The following is a description of a gene set: species: Homo sapiens The synthesis or release of any molecular mediator of the immune response, resulting in an increase in its intracellular or extracellular levels. Human Gene Set: GOBP_PRODUCTION_OF_MOLECULAR_MEDIATOR_OF_IMMUNE_RESPONSE, and this is the list of marker genes: TCF3, POLL, B2M, F2RL1, XCL1, STAT6, FFAR3, BATF, CLCF1, CD86, PRKDC, UNG, SAMHD1, CAMK4, IRAK3, GATA3, CD22, NFKBIZ, SANBR, APOA1, PMS2, IL4, IL17A, CD7, MZB1 (NCBI Gene Id 51237), ATG9A, POLM, CALHM6 (NCBI Gene Id 441168), IFNA2, SHLD3, CD40LG, SASH3, AICDA, KLK7, NHEJ1, IL6, MSH3, KMT5C, IL2RG, NLRP3, EXOSC6, PRKCZ, RIGI, EPHB2, ELANE, LILRB1, POLB, PLCG2, TWIST1, IL18, STX4, CD74, TICAM1, IFNB1, RAET1G, KMT5B, TLR3, TP53BP1, SEMA7A, GPI, SHLD2 (NCBI Gene Id 54537), CGAS, TRAF3IP2, SMAD7, PHB1, IL27RA (NCBI Gene Id 9466, interleukin 27 receptor subunit alpha), NOD1, CYREN, MSH6, MCM3AP, TNF, BTK, ZPBP2, CD226, SWAP70, PRG2, CLNK, BCL6, XRCC4, IL21, PKN1, HK1, ARID5A, TNFRSF14, YY1, IL13RA1, ANGPT1, CLEC7A, UBE2J1, VAMP3, SLC7A5, NLRX1, AXL, SPON2, MMP7, TMBIM6, RTN4, BCL10, CTNNBL1, TREX1, ATG5, SIRT1, CCR6, TRIM6, APOA2, TNFRSF1B, IL33, LILRB4, LITAF, CD244, SLAMF1, MAPKAPK2, ATAD5, CD36, SHLD1, PARP3, HFE, LGALS4, SPHK2, MAP3K7, NBN, EXOSC3, MIR302A, HLA-G, TLR4, JAK3, IL10, POLQ, IL1R1, IL18R1, P2RX7, CD81, C17orf99, EPX, CD28, IL17F, HLA-A (NCBI Gene Id 3105), PCYT1A, MLH1, ARG1, ERCC1, DEFB131A, MIF, KIR2DL4, TLR9, RBP4, PKP3, TRPM4, MYD88, HSPD1, IL5, DDX21, NSD2, CD40, MAD2L2, HLA-F, RNF168, FCGR2B, EXO1, IL13, FZD5, RNF8, IL13RA2, NR4A3, TRIL, LACC1, FCRL3, LAPTM5, DENND1B, TBX21, DDX1, KLK5, NOD2, BST2, GPRC5B (NCBI Gene Id 51704), CD160, TLR7, SCIMP, NDFIP1 (NCBI Gene Id 80762), PTPRC, MAVS, DNAJB9, INAVA (innate immunity activator), APLF, RABGEF1, PAXIP1, KLK3, PANX1, LIG4, CD55, PYCARD, RIPK2, CARD9, CCR2, KIT, CD96, MALT1 (MALT1 paracaspase), DHX36, CR1, TNFRSF4, FFAR2, FOXP3, CD37, TRAF6, RIF1, GALNT2 (NCBI Gene Id 2590), HPX, SECTM1, EVPL, FCER1G, TFRC, IL2, CUEDC2, TRAF2, HLA-E, SYK, WNT5A, TGFB1, TGFB3, SPINK5, PGC, SUPT6H, MSH2, SLC15A4, TNFSF4, HTR2A, PHB2, IL4R, TGFB2, RSAD2, HMCES, ACP5, XBP1, CLC, TNFSF13 (NCBI Gene Id 8741), IRF5, IL1B